The following is a description of a gene set: from publication Yevshin I, Sharipov R, Kolmykov S, Kondrakhin Y, Kolpakov F (PMID 30445619) Genes containing one or more binding sites for (WIZ) in their promoter regions (TSS -1000,+100 bp) as identified by GTRD version 20.06 ChIP-seq harmonization. Human Gene Set: WIZ_TARGET_GENES species: Homo sapiens, and this is the list of marker genes: GTPBP10, ROCK1, MIR3925, CASKIN2, ENSG00000253470, DIP2C, PPP2R5C, PRKCH, CWH43, FLCN, LCP1, CYP1D1P, SENP5, FAM66C, G6PC1, TBC1D9B, ILK, RNU6-199P, ZSWIM1, BRPF3-AS1, PPIP5K2